The following is a description of a gene set: species: Homo sapiens Mild fetal ventriculomegaly A kind of ventriculomegaly occurring in the fetal period and usually diagnosed by prenatal ultrasound. Cerebral ventriculomegaly is defined by atrial measurements 10 mm or more. Mild ventriculomegaly (MVM) is defined as measurements between 10 and 15 mm. Measurements are obtained from an axial plane at the level of the thalamic nuclei just below the standard image to measure the BPD . Human Gene Set: HP_MILD_FETAL_VENTRICULOMEGALY, and this is the list of marker genes: CDC42BPB, ASXL2, MYT1L, DPYSL5, MRPS16